Given this list of marker genes WWC1, RERE, MCUR1, KLF6, ZNF33B, FARP1, GRIN3A, MNT, TTBK1 (tau tubulin kinase 1), ST3GAL1, CACNA1H (calcium voltage-gated channel subunit alpha1 H), IREB2, GRAMD1B, THAP5, TPCN1, PPIP5K1, ELK1, SEPTIN3, RPP14, TREM1, PHLDB1, FLNA, CEP170B, ATP5MF-PTCD1, OSBP2, DIPK1B, TACC1, TRMT61A, SMPD3, DOK3, ZMYND12, PLXNA2, L3MBTL2, DPY19L1, DISP2, SLC26A2, RHOQ, GUCD1 (guanylyl cyclase domain containing 1), OPA3, CLOCK, GLYCTK, ORAI2, IGF2BP1, CBX5, PPFIA2, SHROOM4, LUC7L2, SH3PXD2A, ADCY1, PPP3R1, SDC3, IGFBP5, RPRD1A, ZFP91, DEDD2, EFNB3, ZDHHC22, HYDIN, SEZ6, ZNF281, DPYSL5, KDM3B, POTEM, CCDC28A (NCBI Gene Id 25901), RNF43, HJV, MYEF2, SIK2, TIMM23, SKP2, AAK1, UNC13D, PLXNA4 (NCBI Gene Id 91584), TECPR2, MFAP1, POU2F1, ANKS1A, HEYL, NECTIN1, MYL12A, PHACTR4 (NCBI Gene Id 65979), KRT85, ZNF329, CLNS1A, PEDS1, MPI, RARB, CORO1C, CCDC3, CHD2, PSD2, EPS15L1, TCP10L2, CFH, ARGFX, ZNF827, DGAT2L6, SSH2, ASCC2, AGO3, FMC1-LUC7L2, PITPNM2, ST8SIA5, SLC7A14, ZNRF3, KLHL42, HSPB6, ATG13, ST6GAL1, GLS, MYLK4, SPRED2, N4BP1, SPOCK2, ADPGK, SUSD6 (sushi domain containing 6), RASGEF1A, BCL11A, DDAH1, TRIM40, PPIL2, UGT3A2, DUSP8, NTRK3, STUM, PTCD1, STAMBP, PARP16, UBOX5, VASH1, SDHAF3, MLEC, MBD2, TSHZ2, RSPRY1, SYT1, PRADC1, PLEKHM3, TMEM248, AGO1, ZDHHC7, SEMA6C, PPP1R3B, SINHCAF (SIN3-HDAC complex associated factor), GRM4, BLTP3B, XPO6, PURA, YY1AP1, FAM222B, FCRLA (Fc receptor like A), BMX, here is a description of the gene set: Human Gene Set: MIR3652 from publication Chen Y, Wang X (PMID 31504780) Genes predicted to be targets of miRBase v22 microRNA hsa-miR-3652 in miRDB v6.0 with MirTarget v4 prediction scores > 80 (high confidence targets). species: Homo sapiens